Given this list of marker genes Oprm1, Gipr, Cnr2, Crtc3, Ghrh, Taar5 (NCBI Gene Id 215854), Ptgir, Adcy5, Cnr1, Gna13, Chga, Tbxa2r, Nherf1, S1pr2, Gpr101, Gpha2, Abca1, Cxcl10, Adcy7, Galr2, Gpr119, Adcy6, Pde10a, Prkaca, Pth, Aplp1, Or4m1 (NCBI Gene Id 258658), Adgrl1, Gpr3, Grk2 (NCBI Gene Id 11557), Adgrg3, Gpbar1, Htr6, Taar7d, Adgrf1, Ffar4, Adrb2, Pde3a, Mrgprd (MAS-related GPR, member D), Vipr2, Rit2, Adra1b, Adgrd1, Adgrg1, Or51e2, Adra1a, Cxcl11, Atp2b4, Pln, Adgre5 (adhesion G protein-coupled receptor E5), Adgrf3, App, Rapgef4, Calca, Tshr, Lpar3, Gcgr, Gpr62, Gnaq, Adgrf5, Drd5, S1pr5, Ptger4, Crhr1, Vip, Adm, Mrap, Mrap2, Adgrg5, Adcy2, Fshr, Arrdc3, Dgkq, Grk5, Tmem116, Adgrl3, Adora2b, Pde4a, Agt, Ramp2, Cxcl9, Adcy9, Drd3, Sctr, Gper1, Gpr161, Gip, S1pr3, Gpr65, Htr5a, Ucn2, Adgrf4, Mc3r, Adgrg6, Rack1, Oprl1, Adora2a, Pde4d, Sstr4, Gpr61, Rxfp2, Ucn3, Rxfp1, Ptger1, Adgrf2, Adra1d, Calcr, Gprc6a, Drd1, Ptger2, Cxcr3, Mc5r, Nme2, Adrb1, Vipr1, Adgrb1, Mas1, Lpar1, Adgrg2, Gnas, Adgre1, Adgre4, Calcb, Mc2r, Taar6, Gnal, Adgrl4 (NCBI Gene Id 76321), Lpar2, Adcyap1, Rapgef2, Ramp3, Nos1, Taar1, Ghrhr, Galr1, Pomc, Adrb3, Gpr12, Iapp, Pthlh, Gpr157, Prkar1a, Ptger3, Ptgfr, Gcg, Adcy3, Gpr6, Adgrl2, Adgrg4, Gnai2, S1pr1, Adgrb3, Oprd1, Calcrl, Sct, Htr4, Adm2, Lhcgr, Ramp1, Gsk3a, Adcy1, Pf4, Adcy8, S1pr4, Gphb5, Pth1r, Adcy4, Mgrn1, Prkar2b, Pde2a, Glp1r, Adgrb2, Mc1r, Htr7, Adgrg7, Mc4r, Adcyap1r1, Gpr4, Taar9, Prkar1b, Tcp11, Gpr26, Prkar2a, here is a description of the gene set: A G protein-coupled receptor signaling pathway in which the signal is transmitted via the activation of adenylyl cyclase activity which results in an increase in the intracellular concentration of cyclic AMP (cAMP). This pathway is negatively regulated by phosphodiesterase, which cleaves cAMP and terminates the signaling. studied in species Mus musculus Mouse Gene Set: GOBP_ADENYLATE_CYCLASE_ACTIVATING_G_PROTEIN_COUPLED_RECEPTOR_SIGNALING_PATHWAY